The following is a description of a gene set: Any process that modulates the frequency, rate or extent of renin secretion into blood stream. studied in species Mus musculus Mouse Gene Set: GOBP_REGULATION_OF_RENIN_SECRETION_INTO_BLOOD_STREAM, and this is the list of marker genes: Gja5, F2rl1, F2r, Or51e2, Kcnn4